The following is a description of a gene set: species: Homo sapiens Genes having at least one occurrence of the motif TRTTTGYTYWN in the regions spanning 4 kb centered on their transcription starting sites. This matches the FOXA1 transcription factor binding site V$HNF3ALPHA_Q6 (v7.4 TRANSFAC). Human Gene Set: HNF3ALPHA_Q6, and this is the list of marker genes: TOB1, CDKN1A, ARHGAP30, LRP5, NEBL, AFF3, MACROH2A1, LINC00314 (long intergenic non-protein coding RNA 314), SMARCA2, RTL9, NDST2 (NCBI Gene Id 8509), PAFAH1B3, C8B, VGLL3, YRDC, ESRP2, GOLGA1, CHCHD7, IRX5, LINC00474, VTN, SLITRK2, NSG2, PRDX5, PDCD4, SARM1, PALMD, MAP3K13, PRKAG1, ZMYND8, BOK, KLF3-AS1, COL13A1, MAF, NAV3, SPIB, MGLL, PLA2G1B, NMNAT2, ZNF436, FGF13, GCNT2, HOXB3, IL18, FOXP2, MAB21L3, CP, MEF2C, TRIB1, HOXC4, RBP3, TNR, SREK1, NIM1K, WNT4, SLC39A8, C5, DNASE2B, TENM1, DEPDC7, FOXA2, BCL11B, TCF7L2, PTGR3, CDC42EP3, EGR2, REPS2, ADAMTS14, TSHZ3, CELF4, SPDEF, ANGPTL1, H2AZ2, MCC, TLE1, GBX2, TPP2, KCNQ5, BEND6, FABP4, PRICKLE3, BDH1, MSTN, TAFA1, HMCN1, NKD1, PPP1CB, TLE3, CRH, PTPRG, SCML1, CHD2, PATL1, GPRIN3, GABARAPL1, ABI1, PACSIN3, CCN1, SGK3, ZG16, LUC7L, UNG, DMD, CALD1, C1QA, TYRO3, PIK3C2A, LRRTM3, ALDH9A1, TBXAS1, KDM6A, RBM47, TWIST2, ALG10, TWIST1, KLF12, JADE1, SSH3, BUB3, PDE4D, GAL3ST4, PCDH17, CLDN2, EBF2, EVA1A, XPO4, PITX2, POGZ, UHRF2, OTP, MYL1, BAIAP2, ACACA, VASN, KRT17, TJP1, TET2, ATOH8, KLF3, PHEX, FOXB1, SMPX, AKT3, SGK1, CHRDL1, PLAG1 (NCBI Gene Id 7996), VSIG2, ZBTB37, SRGN, NEUROD2, FOXP1, LCP2, RGMA, PRDM1, DUSP6, STAP1, BAMBI, PURA, C4orf19, C1orf43, CHD6, GATA6, WNT5A, HSF2, HOXA11 (homeobox A11), GNAZ, NEIL3, HOXB8, C1orf122, ADTRP, GPM6A, FOXJ3, GNAO1, CYP7A1, SYN3, ZHX2, TMEM209, NRAS, OTX2, SOX15, MIDEAS, NEO1, CSRNP3, NFIA, ELAVL4, ARHGEF2, HAPLN1, TBX4 (NCBI Gene Id 9496), NOVA1, KCTD15, STOML2, ATOH1, TRMT112, FGF9, ITPKB, FEZF2, NR4A3 (nuclear receptor subfamily 4 group A member 3), PUM2, RREB1, TFDP2, SNX25, FBXL22, TGFB3, ERRFI1, GTF2A1, ITGA3, CADM2, FARP1, ID1, FOXN1, TAF5L